The following is a description of a gene set: Mouse Gene Set: GOBP_POSITIVE_REGULATION_OF_GLIAL_CELL_DIFFERENTIATION Any process that activates or increases the frequency, rate or extent of glia cell differentiation. species: Mus musculus, and this is the list of marker genes: Mdk, Tenm4, Csf1r, Il34, Nkx6-2, Trp73, Prmt5, Ptpra, Bag1, Il33, Tnfrsf1b, Olig2, Zfp488, Notch1, Rela, Ptprz1, Mag, Gsx2, Bmp2, Rnf112, Nkx6-1, Rheb, Qki, Clcn2, Actr3, Prpf19, Id2, Mir23a, Shh, Rtn4, Dicer1, Dag1 (NCBI Gene Id 13138), Clcf1, Bin1, Myrf, Aspa, Lif, Serpine2, Hdac2, Spint1, Egr2, Enpp2, Il1b, Nkx2-2os, Tlr2, Cxcr4, Mir219a-1, Tgfb1, Nkx2-2, Hdac1, Mtor, Hes1, Pparg, Il6st, Zfp365, Ptn, Mir219a-2, Ntf3